The following is a description of a gene set: studied in species Homo sapiens A microtubule-based process that results in the transport of proteins. Human Gene Set: GOBP_MICROTUBULE_BASED_PROTEIN_TRANSPORT, and this is the list of marker genes: CLIP3, BAG3, MAP1A, SPAG17, KIF5C, KIF5A, CEP131, NETO1, DLG2, MAPK8IP3, CAMSAP3, KIF5B, HSPB1, RAB27B